Given this list of marker genes Atf3, Zfp871, Etfb, Rnf130, Fos (FBJ osteosarcoma oncogene), Wdfy2, Niban1, Ccdc88a, Aff4, Cd44, Supt5, Gdi2, Nap1l1, here is a description of the gene set: from publication Cui A, Huang T, Li S, Ma A, Pérez JL, Sander C, Keskin DB, Wu CJ, Fraenkel E, Hacohen N (PMID 38057668) Genes negatively differentially expressed in cell type: cDC2 (conventional dendritic cell type 2) upon treatment with cytokine: IFN-κ in mouse lymph nodes in vivo. studied in species Mus musculus Cytokines mediate cell-cell communication in the immune system and represent important therapeutic targets. A myriad of studies have highlighted their central role in immune function, yet we lack a global view of the cellular responses of each immune cell type to each cytokine. To address this gap, the authors created the Immune Dictionary, a compendium of single-cell transcriptomic profiles of more than 17 immune cell types in response to each of 86 cytokines (>1,400 cytokine-cell type combinations) in mouse lymph nodes in vivo. A cytokine-centric view of the dictionary revealed that most cytokines induce highly cell-type-specific responses. For example, the inflammatory cytokine interleukin-1β induces distinct gene programmes in almost every cell type. A cell-type-centric view of the dictionary identified more than 66 cytokine-driven cellular polarization states across immune cell types, including previously uncharacterized states such as an interleukin-18-induced polyfunctional natural killer cell state. Mouse Gene Set: CUI_CDC2_IFNK_RESPONSE_DN